The following is a description of a gene set: The regulated exocytosis of secretory granules containing preformed mediators such as perforin and granzymes by a natural killer cell. Mouse Gene Set: GOBP_NATURAL_KILLER_CELL_DEGRANULATION species: Mus musculus, and this is the list of marker genes: Nkg7, Lgals9 (lectin, galactose binding, soluble 9), Cd160, Kctd9, Stx11, Ap1g1, Fcgr4, Rab27a, Lamp1, Coro1a, Unc13d